Given this list of marker genes Cflar, Lims1, Selplg, Prkaa2, Stk4, Ppara, Adar, Rb1, Prkaa1, Igf1r, here is a description of the gene set: Mouse Gene Set: GOBP_REGULATION_OF_HEPATOCYTE_APOPTOTIC_PROCESS studied in species Mus musculus Any process that modulates the frequency, rate or extent of hepatocyte apoptotic process.